The following is a description of a gene set: GPCRs, other Mouse Gene Set: WP_GPCRS_OTHER species: Mus musculus, and this is the list of marker genes: Fzd9, Oprl1, Or8d1, Or2a57, Htr1a, Or1ad8, Htr1d, Cnr1, Cysltr1, Or2n1e, Vipr1, Or2w1, Fzd1, Vmn1r171, Or51a10, Vmn1r10, Gpr143, Calcr, Vmn1r13, Vmn1r53, Or2b6, Gabbr1, Vmn1r54, Adrb1, Or3a1c, Adgrg1, Or7a42, Or2t1, Drd1, Or7a40, Or7a37, Adora1, Irx6, Or2z2, Adora3, Or5g26, Vmn1r25, Rrh, Grm1, Ednra, Ltb4r2, Or1j21, Or13a28, Tacr3, S1pr5, Or1e1f, Ackr1, Vmn1r45, Vmn1r172, Vmn1r15, Or2a7, Vmn1r42, Oprk1 (NCBI Gene Id 18388), Vmn1r148, Celsr1, Or1d2 (NCBI Gene Id 258153), Or51a5, Or13a18, Vmn1r46, Or10p22, Pth2r, Or9s13, Ccr10 (NCBI Gene Id 12777), Ghsr, S1pr1, Vmn1r48, Or7e165, Adgrf4, Gpr39, Or1j1, Vmn1r52, V1ra8 (NCBI Gene Id 113850), Mrgprh, Casr, Or1e35, Or1e17, Or3a1, Or6b9, Vmn1r62, Vmn1r14, Vmn1r41, Gpr162, Or4b1d, Or1m1, Vmn2r104, Vmn2r32, Trhr2, Vmn1r63, Celsr3, Or1e34, Or8u8, Mc4r, Vmn1r58, Or13a17, Vmn1r51, Or7a41, Prokr1, Or1a1b, Gpr132, Or51a39, Or4c58, Vmn1r47, Gpr84, Fzd7 (frizzled class receptor 7), Gpr34, Or1p1, Adgre5 (NCBI Gene Id 26364), Or13p10, Vmn1r56, Or7e178, Vmn1r50 (vomeronasal 1 receptor 50), Gpr37l1, Fzd5, Vmn1r11, Drd5, Xcr1, Smo, Gpr165, Sstr5, Vmn1r40, Or8c9, Drd2, Or8g19, Celsr2, Or1e23, Vmn1r49, Adrb2, Vmn1r65, Or6z7, Mtnr1b, Vmn1r29, Or2y1b, Gpr83, Oprm1 (opioid receptor, mu 1), Or8g20, Or1f19, Vmn1r44, Or1a1, Or13a27, Or2ag2b, Gpr146, Tas1r1, Gpr88, S1pr2 (NCBI Gene Id 68430), Tmigd3, Ccr7, Or1x2 (olfactory receptor family 1 subfamily X member 2), Or1e16, Vmn1r43, Vmn2r107, Fzd2, Or6a2